Given this list of marker genes CXCL12, HTR2A, GRM2, SNCG, DRD2 (NCBI Gene Id 91906), NPY2R, GNAT1, SYT11, CHRNA6, PINK1 (NCBI Gene Id 65018), GABBR1, SYT1, COMT, DTNBP1, CHRNA4, SNCA, KCNA2, PRKN, TGM2, SLC18A2, SYT4, ABAT, DRD3, KPNA4, CHRNB2, GDNF, FGF20, OPRK1, here is a description of the gene set: species: Homo sapiens Human Gene Set: GOBP_DOPAMINE_SECRETION The regulated release of dopamine by a cell. Dopamine is a catecholamine and a precursor of adrenaline and noradrenaline. It acts as a neurotransmitter in the central nervous system but it is also produced peripherally and acts as a hormone.